Given this list of marker genes RAB13, FLNA, ARID4A, ABCB1, ARID4B, here is a description of the gene set: Establishment of a structure near the basement membrane in adjacent Sertoli cells of the seminiferous epithelium for maintaining spermatogenesis. The structure consists of tight junctions, basal ectoplasmic specializations, and desmosome-like junctions. studied in species Homo sapiens Human Gene Set: GOBP_ESTABLISHMENT_OF_SERTOLI_CELL_BARRIER